Given this list of marker genes EXOC1, EIPR1, AKTIP, HOOK2, TRAPPC1, TRAPPC14, VPS18, COG6, VPS41, EXOC3L4, TRAPPC6A, RINT1, VPS53, TNFAIP2, EXOC3L2, EXOC8, COG1, EXOC2, TRAPPC2B, WASHC1, COG7, EXOC3, VIPAS39, VPS33B, TMEM115, TRAPPC8, COG2, TRAPPC3L, EXOC6B, EXOC7 (exocyst complex component 7), HOOK3, TRAPPC10, EXOC6, COG8, EXOC3L1, STX17, TRAPPC2, MYRIP, TRAPPC5, TGFBRAP1, VPS39, TRAPPC3, HOOK1, TRAPPC11, TRAPPC2L, EXOC5, VPS16, RAB10, TRAPPC12, TRAPPC4, TRAPPC13, SH3BP1, VPS52, VPS11, EXOC4, CDC42, COG5, VPS54, TRAPPC9, NBAS, ZW10, COG3, VPS51, COG4, TRAPPC6B, VPS8, VPS33A, here is a description of the gene set: Any protein complex that plays a role in vesicle tethering. species: Homo sapiens Human Gene Set: GOCC_VESICLE_TETHERING_COMPLEX